Given this list of marker genes HERC2, LIFR, ATP1A2, PRPS1, ELP1 (NCBI Gene Id 8518), FLII, LMX1B, SH3TC2, RFC1, NLRP3, VCP, MKRN3, HSPB1, SNORD115-1, CCT5, SPTLC1, WNK1, PDK3, MADD, TDP1, JAG1, PNPT1, GRIN2A, UBTF, DEAF1, HK1, PRDM12, NPAP1, SCYL1, ZFTA, DSE, RAI1, MPZ, KIF1A, H19, HNRNPK, PWRN1, CLTCL1, IARS2, SCN9A, AIFM1, KCNQ1OT1, SYNGAP1, SCN11A (sodium voltage-gated channel alpha subunit 11), MFN2, NGF, SCN1A, TRPM3, SNORD116-1, DDHD1, NTRK1, KDM5C, SRPX2, PRRT2, ZEB2, IQSEC2, ATL3, RFX7, MEN1, MPV17, ALDH4A1, NTNG1, GNB4, ABCD1, PRNP, DKK1, CACNA1A, CHST14, RNF170, PDXK, NKX6-2, ALDH18A1, MAGEL2, YY1, PMP22, CACNA2D1, SDHA, RETREG1, NGLY1, ZFHX2, PMP2, EBF3, IGF2, MECP2, GJB1, MCM3AP, GRIA3, FMR1, DNM1L, FBN1, HDAC4, ATXN1, TMEM218, CDKL5, HARS1, SNUPN, NEFL, GDAP1, CHAMP1, ATL1, ABCA1, SMC1A, SORD, GABRG2, SCN10A, TRIO, PWAR1, PEX16, SHANK3, SPTLC2, GABBR2, here is a description of the gene set: species: Homo sapiens Abnormality of pain sensation Human Gene Set: HP_ABNORMALITY_OF_PAIN_SENSATION Pain is an unpleasant sensation that can range from mild, localized discomfort to agony, whereby the physical part of pain results from nerve stimulation and is often accompanied by an emotional component. This term groups abnormalities in pain sensation presumed to result from abnormalities related to the specific nerve fibers that carry the pain impulses to the brain.